The following is a description of a gene set: part of: Oncogenic MAPK signaling species: Homo sapiens Reactome Pathway: Signaling by BRAF and RAF1 fusions In addition to the more prevalent point mutations, BRAF and RAF1 are also subject to activation as a result of translocation events that yield truncated or fusion products. In general these events put the C-terminal kinase domain of BRAF or RAF1 downstream of an N-terminal sequence provided by a partner protein. This removes the N-terminal region of the RAF protein, relieving the autoinhibition imposed by this region of the protein. In addition, some but not all of the fusion partner proteins have been shown to contain coiled-coil or other dimerization domains. Taken together, the fusion proteins are thought to dimerize constitutively and activate downstream signaling., and this is the list of marker genes: ZC3HAV1, ITGA2B, ATG7, MAP2K2, CAMK2A, TRIM24, LMNA, JAK2, IQGAP1, CAMK2G (calcium/calmodulin dependent protein kinase II gamma, NCBI Gene Id 818), RAF1, VWF, TENT4A, HRAS, APBB1IP, CNKSR1, CNKSR2, MPRIP, KSR1, MAPK1, MAPK3, CALM1, ARRB2, BRAF, FGA (fibrinogen alpha chain), KDM7A, MAP2K1, KRAS, NRAS, CAMK2D, AGK, CLCN6, CAMK2B, VCL, ARRB1, BCL2L11, FGB, PEBP1, CSK, FXR1, AKAP9, ACTB, AGTRAP, AP3B1, ITGB3, RAP1B, AGGF1, FN1, PAPSS1, ESRP1 (epithelial splicing regulatory protein 1), QKI, TRAK1, TLN1, ACTG1, MARK3, KSR2, FGG, SRC, FAM114A2, ARAF, RAP1A, SND1, KIAA1549, YWHAB, FAM131B